Given this list of marker genes SERPINE2, CXCL8 (NCBI Gene Id 3576), CDH2, FABP4, CADM1, CNN1, EDIL3, NPPB, IGFBP3, TNFAIP3 (TNF alpha induced protein 3), MX1, ASAH1, ABI3BP, NDRG4, LRP1, QSOX1, FBN1, OLFML3, P3H2, IER3, FUCA1, BDNF (NCBI Gene Id 627), DKK3, DMD, CREB3L1, TGFB2-OT1, TSPAN2, NNAT (neuronatin), FILIP1, COL6A1, ADM, RELB, IL32, IGFBP7, FAT1, INHBA, COL4A2, GADD45A, CPE, ITM2B, GABRA1, ASS1, ICAM1, USF1, FTH1, IL6, COL2A1, NUAK1, TACSTD2, TGFA, CDKN1A, IFI27, HLA-C, APOE, UCP2, ADA, CLIP3, CUX1, TMEM45A, ITGA3, CCL11, CLU, F2RL2, SDC4, IGF2R, SLCO1A2 (NCBI Gene Id 6579), NPC2, MEFV, VCAN, ACSF2, SMTN, IFI6, TAGLN, CTSB, PDLIM3, CXCL6, CXCL1, here is a description of the gene set: species: Homo sapiens Tumor angiogenesis requires intricate regulation of gene expression in endothelial cells. We recently showed that DNA methyltransferase (DNMT) and histone deacetylase (HDAC) inhibitors directly repress endothelial cell growth and tumor angiogenesis, suggesting that epigenetic modifications mediated by DNMTs and HDAC are involved in regulation of endothelial cell gene expression during tumor angiogenesis. To understand the mechanisms behind the epigenetic regulation of tumor angiogenesis, we used microarray analysis to perform a comprehensive screen to identify genes down-regulated in tumor-conditioned versus quiescent endothelial cells, and reexpressed by 5-aza-2'-deoxycytidine (DAC) and trichostatin A (TSA). Among the genes identified, 77% harbored a promoter CpG island. Validation of mRNA levels of a subset of genes confirmed significant down-regulation in tumor-conditioned endothelial cells and reactivation by treatment with a combination of DAC and TSA, as well as by both compounds separately. Silencing of these genes in tumor-conditioned endothelial cells correlated with promoter histone H3 deacetylation and loss of H3 lysine 4 methylation, but did not involve DNA methylation of promoter CpG islands. For six genes, down-regulation in microdissected human tumor endothelium was confirmed. Functional validation by RNA interference revealed that clusterin, fibrillin 1, and quiescin Q6 are negative regulators of endothelial cell growth and angiogenesis. In summary, our data identify novel angiogenesis-suppressing genes that become silenced in tumor-conditioned endothelial cells in association with promoter histone modifications and reactivated by DNMT and HDAC inhibitors through reversal of these epigenetic modifications, providing a mechanism for epigenetic regulation of tumor angiogenesis. from publication Hellebrekers DM, Melotte V, Viré E, Langenkamp E, Molema G, Fuks F, Herman JG, Van Criekinge W, Griffioen AW, van Engeland M (PMID 17483324) Human Gene Set: HELLEBREKERS_SILENCED_DURING_TUMOR_ANGIOGENESIS Genes down-regulated in tumor-conditioned vs quiescent endothelial cells and up-regulated upon treatment with decitabine and TSA.